The following is a description of a gene set: species: Mus musculus Any process that stops or reduces the rate of oxidoreductase activity, the catalysis of an oxidation-reduction (redox) reaction, a reversible chemical reaction in which the oxidation state of an atom or atoms within a molecule is altered. Mouse Gene Set: GOBP_NEGATIVE_REGULATION_OF_OXIDOREDUCTASE_ACTIVITY, and this is the list of marker genes: Cav1, Cyp27b1, Snca, Atp2b4, Gla, Gfi1, Nosip, Cav3, Ins1, Prkn, Prdx5, Nfkb1, Eng, Oxa1l, Slc4a1, Drd5, Gzma, Mt3, Ins2